The following is a description of a gene set: The midline of aligned thick filaments in a sarcomere; location of specific proteins that link thick filaments. Depending on muscle type the M band consists of different numbers of M lines. Mouse Gene Set: GOCC_M_BAND studied in species Mus musculus, and this is the list of marker genes: Myom3, Mybpc2 (myosin binding protein C, fast-type), Nbr1, Kctd6, Trim63, Ttn, Ank2, Smpx, Cryab, Klhl41, Ank1, Cmya5, Aldoa, Smtnl1, Mybph, Myom1, Myom2, Fhl2, Mybpc3, Ppp2r5a, Mybpc1, Obscn (NCBI Gene Id 380698), Lmod3 (NCBI Gene Id 320502), Lrrc39, Hspb1, S100a1 (S100 calcium binding protein A1), Sptbn1, Lmod2, Slmap